Given this list of marker genes Hspa1a, Btg1, Junb, Klf6, Jun, Btg2, Uba52, Hspa1b (NCBI Gene Id 15511), Ppp1r15a, Fos, here is a description of the gene set: Mouse Gene Set: CUI_T_CELL_CD4_NOGGIN_RESPONSE_DN Cytokines mediate cell-cell communication in the immune system and represent important therapeutic targets. A myriad of studies have highlighted their central role in immune function, yet we lack a global view of the cellular responses of each immune cell type to each cytokine. To address this gap, the authors created the Immune Dictionary, a compendium of single-cell transcriptomic profiles of more than 17 immune cell types in response to each of 86 cytokines (>1,400 cytokine-cell type combinations) in mouse lymph nodes in vivo. A cytokine-centric view of the dictionary revealed that most cytokines induce highly cell-type-specific responses. For example, the inflammatory cytokine interleukin-1β induces distinct gene programmes in almost every cell type. A cell-type-centric view of the dictionary identified more than 66 cytokine-driven cellular polarization states across immune cell types, including previously uncharacterized states such as an interleukin-18-induced polyfunctional natural killer cell state. studied in species Mus musculus Genes negatively differentially expressed in cell type: CD4+ T cell upon treatment with cytokine: Noggin in mouse lymph nodes in vivo. from publication Cui A, Huang T, Li S, Ma A, Pérez JL, Sander C, Keskin DB, Wu CJ, Fraenkel E, Hacohen N (PMID 38057668)